The following is a description of a gene set: Aplasia of the semicircular canal Absence of the semicircular canal. Human Gene Set: HP_APLASIA_OF_THE_SEMICIRCULAR_CANAL species: Homo sapiens, and this is the list of marker genes: RRAS2 (RAS related 2), LZTR1, CBL, MRAS, RAF1, CHD7, NRAS, PTPN11, KDM6A, RASA2 (NCBI Gene Id 5922), RRAS, SOS1, RIT1, KMT2D, KRAS, SOS2, SPRED2, SOX10